The following is a description of a gene set: species: Mus musculus Murine embryonic stem (ES) cells are defined by continuous self-renewal and pluripotency. A diverse repertoire of protein isoforms arising from alternative splicing is expressed in ES cells without defined biological roles. Sall4, a transcription factor essential for pluripotency, exists as two isoforms (Sall4a and Sall4b). Both isoforms can form homodimers and a heterodimer with each other, and each can interact with Nanog. By genomewide location analysis, we determined that Sall4a and Sall4b have overlapping, but not identical binding sites within the ES cell genome. In addition, Sall4b, but not Sall4a, binds preferentially to highly expressed loci in ES cells. Sall4a and Sall4b binding sites are distinguished by both epigenetic marks at target loci and their clustering with binding sites of other pluripotency factors. When ES cells expressing a single isoform of Sall4 are generated, Sall4b alone could maintain the pluripotent state, although it could not completely suppress all differentiation markers. Sall4a and Sall4b collaborate in maintenance of the pluripotent state but play distinct roles. Our work is novel in establishing such isoform-specific differences in ES cells. Mouse Gene Set: RAO_BOUND_BY_SALL4_ISOFORM_B from publication Rao S, Zhen S, Roumiantsev S, McDonald LT, Yuan GC, Orkin SH (PMID 20837710) Loci bound exclusively by SALL4 isoform b in ES cells (embryonic stem)., and this is the list of marker genes: Rp1l1, Edem1, Ptch2, Pdlim1, Ift57, Ipo7, Wsb2, Pnrc2, Tceal8, Utp14b, Wsb1, Cnot10, Or5j1, Or4k77, Ric8b, Lmntd1, Or5ac17, Hes1, Pif1 (NCBI Gene Id 208084), Or8c8, Etf1, Tor3a, Or1j15, Lhfpl6, Ankrd55, Pipox, Spry4, Dipk2a, Sepsecs, Pef1, Kng2, Eif1a, Il36g, Epha4, Emb, Rbbp7, Pla2g7, Sfrp1, Or8c16, Cct6b, Tex36, Ier2, Bltp2, Lipt1, Ankrd6, Fbxo28, Ndufs1, Chmp4c, Osbp, Palm3, Or2y1c, Zbtb2, Epcip, Ppip5k2, Itpk1, Nostrin, Zw10, Selenoh (selenoprotein H), Chil4, Upf3a, Or7g27, Akap1, Habp4, Rbfox2, Cd180, Clrn1, Or8j3, Gpbp1l1, Mup4, Hs3st3b1, Ctnnb1, Arhgap28, Ccp110, Luzp1, Adap1, Rmnd5a, Vmn2r112, Vangl1, Cer1, Atg10, Zfp219, Samm50, Pclo, Selenoi, Ablim1, Or8b42, Akr1c14 (aldo-keto reductase family 1, member C14), Sulf1, Spag11b, Cd38, Fem1b, Fbxw10, Ccdc60, Gnrh1, Fam107b, Srgap3, Clec2d, Mrfap1, Casp3, Pitx2, Spindoc, Creb3l2 (cAMP responsive element binding protein 3-like 2), Ppp2ca, Zfand1, Hmgxb4, Ccdc88a, Gsta2, Tm9sf4, Bmt2, Slc27a2, Fastkd2, Rtn4, Pacsin2, Ppp1r3b, Tmem39a, Cldn4, Slc25a3, Mindy3, Map7d3, Ifna13, Ostf1, H2bc22, Sall4, Zfp189, Arhgef3, BC048507, Lrrn2, Acot9, Golga1, Dis3l, Clcn3, Shoc2, Zswim1, Ncor1, Primpol, Bmp4, Trim12c, Dmtn, Marchf6, Kifc5b, Fcrl1 (Fc receptor-like 1), Cpeb2, Lmo3, Cggbp1, Ino80, Fut9, 4921517D22Rik, Ckmt1, Itgb3bp, Trh, Rhof, Neurog3, Pcyt1b, Utp4, Vmn1r72, Lamc2, Ankrd10, Gdap1, Ufm1, Aldh3a2, Cacna2d1, Actbl2, Tra2a, Guca2a (guanylate cyclase activator 2a (guanylin)), Pura, Gbp5, 1810030O07Rik, Meis1, Bmpr2, Nat2, Rcan1, Plpp1 (NCBI Gene Id 19012), Ina, Asf1a, C2cd5, Rchy1, Elmo1, Ist1, Gripap1, Obsl1, Wnk1, Adam23, Nkx1-2, Cited2, Pard3 (par-3 family cell polarity regulator), Vcan, Cask (calcium/calmodulin dependent serine protein kinase), Fubp3, Csrnp3, Zfp781a, Snx16, Col6a4, Gdap1l1, Cbx5, Slc19a3, Abcg2, Rerg, Pou5f1, Kit, Tmprss7, G6pc2, Vmn1r230, Pip4p2, ENSMUSG00000121861, Tnfrsf19, Rcbtb1, Olig3, Rcn1 (NCBI Gene Id 19672), Nkain3, G2e3, Vav3, Epn2, Ube2b, Foxd3, Cbx1, Yars2, Efcab2, Phip, Ppp3cc, Asb11 (ankyrin repeat and SOCS box-containing 11), Srsf5, Rmnd1, Rigi, Ugt1a5, Mbtd1, Nsmaf, Mllt6, Snx5, Fbxo32, Iqub, Sp3, M1ap, Mmp11, Npm1, Nsd3, Mtus1, H4c3, Zfp706, Gde1, Dram2, Dedd, Nectin1, Cd274, Slk, Rel, Osbpl9, Arhgap12, Rtn3 (NCBI Gene Id 20168), Zbtb41, Speer4a1, Serpinb6d (serine (or cysteine) peptidase inhibitor, clade B, member 6d), Dnah14, Vmn2r74, Itga3, Prr13, Fkbp9, Mgat3, Edn2, B3gnt5, Eif5a, Aspa, Prrc2a, Or7e177, Stk35, Lrrtm2, Serpinb6c, Ppp1r10, Ppp1r15b, Nrsn1, Ugcg, Ldb1, Gadd45a, Cfap95, Slc3a2, Mrpl11, Lrrcc1, Sfpq, Sinhcaf, Tfdp2, Klhl23, Map4k3, Fosl1, Spp1, Sparcl1, Alms1, Zfp948, Dmrt3, Dennd6a, Zfp788, Nodal, Ifnab, Krcc1, Arid5b, Rnf146, Cipc, Mllt10, Id2 (NCBI Gene Id 97802), St8sia1, Pccb, Znrf3, Irag2, Psme4, Abca4 (ATP-binding cassette, sub-family A member 4), Ro60, Ftdc2, Cd96, Lefty1, Zfp37, Anapc5, Rtn1, Nck1, Cdc7, Or5w22, Ppia, Lyrm2, Or7g25, Ddx17, Mcee, Rps20, Nptn, Prlr, Cd55, Cldn14, Msc, Entpd1, Shcbp1, Npy5r, Fabp2, Top3b, Idua, Inava, Tafa4, Ezh2, Gpr19, Pax6, Tmem67, Vdac3, Or52ab7, Fam117b, Rbm5, Tgif1, Tbl1xr1, Mtcl3, Lmo4, Lbr, Timp4, Slc25a36, Zic3, Nqo2, Ube2e3, Tmem26, Sox30, Morf4l2, Slc6a1, Cbx7, Lpar4, Kif13a, Mcts1, Sdccag8, Ptms, Or5p72, Ccdc68, Sp1, Pcnp, Nkiras2, Osr2, Trmt10a, Ugt2b38, Sh3bp4, Gclm, Tmod3, Vmn2r52, Anln, Ifnk, Edc4, Potefam1, Cr1l, Lrrtm3, Mettl17 (methyltransferase like 17), Naa30, Socs5, Pbld2, Ren1, Hint1, Rb1cc1, Spta1, Rif1 (NCBI Gene Id 99400), Rusc2 (NCBI Gene Id 230094), Rps12, Spred2, Rab18, Tmem230, Col5a2, Tbx18, H1f5, Ctsm, Tubb3, Cd47, Zfp819, Rbm14, Bbs4, Tgm3, S100a7l2, Dcp1b, Skap2, H2bc13, Neurod1, Birc2, Or10a5, Ipo5, Hus1, Moap1, Tubb2b, Zfand6, Zfp64, Hdac9, Gad2, Or8g24, Fundc2, Or7a41, Zranb1, Vmn2r48, Mpzl1, Smad7, Igf2bp1, Nid2, Setd5, Sypl2, Pml, Nfe2l2, Dph6, Rnf125, Mat2b, Adamts6, Dst, Cst13, Npy1r, Grhl3, Dctn6, Hlf, Dcun1d3, Sall3, Tbc1d13, Asxl1, Rai14, Grap2, Fignl1, Rhbdd2, Steap2, Gtf2i, F13b, Or12k5, Efnb2, Itga9, Arl6ip5, Spink6, Porcn, Sptbn1, Ibtk, Ndufa5, L3mbtl3, Zfp428, Klhl31, Etv5, Gpc6, Cnot8, Cep120, Atoh1, Bcl10, Or5k16, Tbc1d9, D030056L22Rik, Atf2, Or12j4, Wnt6, Vmn2r47, Ivns1abp, Myl12b, Psmd7, Gabpb1, Dbf4, Dppa4, Or52p2, Arhgap11a (NCBI Gene Id 228482), Senp2, Cenpn, Spin1, Rbmxl1, Got1l1, H3c8, Irgm1, Tcea1, Hoxa4, Fam120c, Cxcr4, Lefty2, Map3k5, Spink2, Vcpkmt, Bard1, Wapl, Copg2, Tfpi, Ndc1, Or5h25, Hoxb8, Bcar1, Map7, Dnajb6, Nr1h3, Fam162a, Mlh3, Klhl15, Fam204a, Klf9, Pnpla8, AW146154, Shisa2, H1f6, Atcay, Rbpms, Rfx4, Ovol2 (NCBI Gene Id 69059), Dpp10, 4933436I01Rik (RIKEN cDNA 4933436I01 gene), Gap43, Tspan9, Tle3, Efhb, Tead1, Mllt3, Tcf7l1, Btn2a2, Ptpn12, Gsdma3, Rbpj, Lypla1, Vmn2r85, Nlrp4a, Tfap2b (transcription factor AP-2 beta), Brpf1, Anxa11, Cenpi, Gpr152, Vmn1r17, Emilin2, Asrgl1, Knl1, Slc2a3, Nfe2l1, Cmas, B3gnt2, Gad1, Ttll4, Coq9, Zfp708, Zcrb1, Or8c20, Hsd17b2, Aox3, Lrrc34, Yap1, Phtf2, Ino80b (INO80 complex subunit B)